Given this list of marker genes CATSPERD, LPAR2, SLU7, MAZ, ELAC1, IL2RA, SETD1A, ZNF235, TEX56P, PHF20L1, ADGB, SLC12A5, LRRC36 (leucine rich repeat containing 36), PIEZO2, FRMPD2 (NCBI Gene Id 414180), RAD18, DPF1, ADAMTS16, RIMS4, MMP7, REG1A, ELP6, PKN1, BMP10, CDH23, FSCN3, PEG10, LCMT2, PUS7, TBX21, GINS2, GPR161, PRM3, FOXA3, NPHP3, PPP1R26, AGAP1, CD28, CYP4X1, USP26, ERICH2, KCNJ1, WFDC2, CENPM, GABRB2, AQP12A, ACTRT2, CFAP184, CES5A, HOXA11 (NCBI Gene Id 3207), ICA1L, SEMA5B, ATXN7L2, RHD, NNT, VGLL4, GRM3, UGT2B4, RAD9B, KHK, CFAP65, RAB39A, FLT4, MSLN, POLRMT, PIERCE1, LYRM9, LEMD1, SPRY4, CALCOCO2, SCN3B, HS3ST2, KANK4, CIMIP5, DPF3, PPFIA2, GP2 (NCBI Gene Id 51724), PDE1C, TBX2, LRRN2, HOXD13, LRTM2, CBFA2T3, SRRM2, ABO, CYB5RL, RGS7, AARS2 (NCBI Gene Id 57505), KCNAB1, KYNU, EPX, BMP8A, CRISP1, CLCA4, M1AP, MROH3P, STMN2, CFAP69, RNF11, KIAA0825, FANCM, TMEM26, MYRF (NCBI Gene Id 84755), WDFY1, HIVEP2, NPEPL1, ROPN1L, FJX1, ENPP6, THAP6, IHH, ARHGEF38, RBP3, FAM168A, SSUH2, RAB3B, AHSG, AZIN2, ADCY10, SNAPC2, DTL, FBXO32, METTL21A, CPLX3, SLC29A2, FSTL5, YJU2B, RAB4A, PMF1, CPOX, SEZ6L2, KPTN, GDPD1, FNDC8, ASCL1, ATOH8, DCDC2B, DNAI3, C2CD5, CRKL, CCL28, FZD4, OXCT2, DDX23, POU3F3, TMEM200C, HECTD2, PIGB, PABPN1L, TBRG4, AVP, SLC35D2, MYPOP, SMIM23 (NCBI Gene Id 651801), ARMC6, TEX55, TH, KIF3C, KBTBD13, SCT, TMEM80, SIDT1, USPL1, MARCHF4 (NCBI Gene Id 57574), ERCC6L, CNTN1, ZNF619, RPH3AL, KCTD18, RAP1GAP2, NPHP1, MYH7B, DGKK, KCNK15, NDP, OGFOD2, CNPY1, PRF1, BCL2L12, MEP1B, COX4I2, REG3G, LRFN3, GEMIN7, RNF157, DRAXIN, CHST8, WDR54, ASPHD1, RIN3, KCNN2, SBNO1, KLHL15, PRIMA1, PWP2, TMEM150B, SORT1, LSM11, LSM12, here is a description of the gene set: species: Homo sapiens Human Gene Set: GSE45365_NK_CELL_VS_CD8A_DC_DN Genes down-regulated in NK cells versus CD8A T cells. Murine Cytomegalovirus (MCMV) infection leads to early activation of various immune cells, including B and T lymphocytes, before the actual initiation of antigen-specific adaptive immunity. This activation is partly driven by innate cytokines, including type I interferon (IFN), which are induced early after infection. The objective of this study was to address the role of type I IFN in shaping early/innate B and T cell responses to a primary acute viral infection. In order to decipher the specific impact of IFN-I on cell subsets, we performed a genome-wide expression analysis on WT splenic B and CD8 T lymphocytes isolated from C57BL/6 mixed bone marrow chimera mice. This study complements series GSE39555, which focused on early responses of NK cells and of the two subsets of conventional dendritic cells.